Given this list of marker genes Fam98a, Mtg1, Ube2q1, Golga7 (NCBI Gene Id 97499), Zbtb41 (zinc finger and BTB domain containing 41), Siglech, Krtap13, Cblb, Top1, Cdc14b, Nectin3, Dzip3, Myef2, Bpnt2, Eya4, Llgl2, Gas2l3, Elk1, Ubr3, Phf12, Cyp1a1, Sall1, Mfsd13a, Defb20, Tmed5, Rbm43, Mb21d2, Zfp872, Pitpnb, Xrn2, Lrrtm2, Bin3, Rnft1, Man2b1, Bach2, Nfe2l2, Pik3r4, Alcam, Nol8, Cul3 (NCBI Gene Id 98674, cullin 3), Fcgrt, Inka2, Itga6, Marchf7, here is a description of the gene set: Mouse Gene Set: MIR_547_5P studied in species Mus musculus from publication Chen Y, Wang X (PMID 31504780) Genes predicted to be targets of miRBase v22 microRNA mmu_miR_547_5p in miRDB v6.0 with MirTarget v4 prediction scores > 80 (high confidence targets).